The following is a description of a gene set: Human Gene Set: GOMF_CYSTEINE_TYPE_ENDOPEPTIDASE_ACTIVATOR_ACTIVITY species: Homo sapiens Binds to and increases the activity of a cysteine-type endopeptidase., and this is the list of marker genes: HSPD1, TIMM50, APAF1, AIM2 (absent in melanoma 2), PYCARD, NLRP1, ST20, NLRP3, NLRP12, BAD, CARD8